Given this list of marker genes GJB2, STAG2, ENPP1, IDS, NOG, NOTCH3, COL1A2, FOXL1, SIX1, GJB6, PSMD12, SIX5 (SIX homeobox 5), SETBP1, TFAP2A, ABCC6, BPTF, IL11RA, EYA1, MAP3K7, POU3F4, RAD21, SMARCA4, GDF6, ANKH, POLR1D, COL1A1, here is a description of the gene set: studied in species Homo sapiens An abnormality of the middle-ear ossicles (three small bones called malleus, incus, and stapes) that are contained within the middle ear and serve to transmit sounds from the air to the fluid-filled labyrinth (cochlea). Abnormality of the middle ear ossicles Human Gene Set: HP_ABNORMALITY_OF_THE_MIDDLE_EAR_OSSICLES